The following is a description of a gene set: Translation factors Mouse Gene Set: WP_TRANSLATION_FACTORS species: Mus musculus, and this is the list of marker genes: Eif3d, Eif4ebp1, Eif4g1, Eif2s2, Eif4e, Pabpc2, Etf1, Eef1d, Eif2b2, Eif4a2, Eif5a, Eif2b5, Eif2ak1, Eif4ebp2, Pabpc1, Eif3c, Eif4a1, Eef1b2 (NCBI Gene Id 80613), Eif4g3, Eif6, Paip1, Eif3i, Eif4b, Eif1a, Eef2, Eef1a1, Eif3e, Eif2s1, Eif4g2, Eif3g (eukaryotic translation initiation factor 3, subunit G), Eif3h, Eif4ebp3, Eif2b1, Eif1, Eif3b, Eif4h, Eif2b3, Eif5, Eif3j1, Eef1g, Eef1a2, Eif2b4, Eif3a, Eif2ak3, Eif2ak2, Eef2k, Eif2s3x, Eif2s3y, Eif3f